Given this list of marker genes Pcsk1, Gpr68, Pfkm, Bsg, Cftr, Pard6a, Lepr, Gpr39, Agt, Dnm1l, Gna11, Gip, Rac1, Ang, Frmd4a, Sirt3, Mlxipl, Sirt6, Isl1, Kif5b, Tgfb2, Pfkfb2, Gcg, Nr1h4, Trpm2 (transient receptor potential cation channel, subfamily M, member 2), A1cf, Orai1, Prkn, Tmem132a, Prkar1a, Hcar2, Fgb, Nnat, Tgfb3, Egfr, Ang2, Tlr2, Tlr4, Oxct1, Arf1, F2rl1, C1qtnf3, Nmu, Anxa7, Golph3, Ang6, Prkaca, Pdx1, Adam9, Rfx6, Trpm5, Myrip, Trpm4, Zfp384, Prkce, Crh, Ttn, Lrp1, Vsnl1, Cacna1d, Atp13a2, Kcnn4, Or51e2, Snap25, Hcfc1, Ptpn23, Trem2, Hif1a, Pla2g6, Prkcq, Jak2, Apbb1, Cd2ap (CD2-associated protein), Fga, Malrd1 (MAM and LDL receptor class A domain containing 1), Tunar (Tcl1 upstream neural differentiation associated RNA), Blk, Slc30a8, Gper1, Ep300, Tm7sf3, Ppia (NCBI Gene Id 268373), Ankrd1, Prkcb, Myom1, Fgg, Gnas, Acsl4, Bad, Gja1, Gnaq, Sec24a, Unc13b, Vamp8, Gck, C1qtnf12 (NCBI Gene Id 67389), Ptger4, Cacna1c, Baiap3, Fto, Plcb1, Ang5, Cd38, Trh, Mmp13, Serp1, Rbp4, Ins1, Camk2n1, Arf6, Ppard, Rapgef4, Vps35, Tmed10-ps, Mcu, Itpr1, Ucn3, Osbp, Myo18a, Cask, Tmed10, Myh9, Tcf7l2, Nr0b2, Lrrc8a, Ffar1 (free fatty acid receptor 1), Bglap2, Il1a, Ppp3cb, Gpld1, Exph5, Sox4, Dynll1, Sirt1, Irs2, Igf1, Abcg1, Abat, F2rl2, Vegfc, Apbb3, Ppid, Hnf1a, Rab34, C2cd2l, Myh10, Wls, Psmd9, Glp1r, Tgfb1, Ier3ip1, Aacs, Nadk, Ncoa6, Gpr27, Rph3al, Stx4a, Ins2, Nr1h2, Il13, F2, Adora2a, Sybu, Gprc6a, Doc2b, Ano1, Ptbp1 (NCBI Gene Id 19205), Ffar2, Adcy8, Stim1, Pparg, Abcc8, Tardbp, Pck2, Nkx6-1, Nlgn2, Glul, Ang4, Ghrl, Atg7, Trpc1 (NCBI Gene Id 22063), Golph3l, Sytl4, Oga, Casr, Arrb1, Capn10, Mpc2, P2rx7, Trpa1, Slc2a2 (solute carrier family 2 (facilitated glucose transporter), member 2), Chrm3, Glud1, Gipr, here is a description of the gene set: Mouse Gene Set: GOBP_POSITIVE_REGULATION_OF_PROTEIN_SECRETION Any process that activates or increases the frequency, rate or extent of the controlled release of a protein from a cell. species: Mus musculus